Given this list of marker genes Il27ra, Ephb6, Pdcd1, Ddx21, H2-T15 (NCBI Gene Id 15030), Pik3r6 (NCBI Gene Id 432574), Ighv2-4 (immunoglobulin heavy variable V2-4), Slc11a1, Ighv1-56, Ighv13-2, Kmt5c, Ighv8-11, Ighv8-9, Slc18a2, Vsir, Nfkbiz, Swap70, Muc4, Klrc3, Ighv8-13, Ighm, Gpr15lg, Ighv8-6, Ighv2-5, Dlg1, Il9, Ighv16-1 (NCBI Gene Id 629812), Fcer1a, Stxbp2, F2, Chga, Ighv3-4, Ighv14-2, Rasgrp4, Prkcz, H2-Q4, Il18rap, Slc22a13, Mrgprx2, Il13ra2, Il21, Exo1, Cd40lg, Was, H2-M10.3, H2-T5, B2m, Stxbp3, Unc13d, Nppc, Vamp2, Il31ra, H2-Q7, Pik3r1, Stard7, Cd1d2, Zp3, Klrb1b, Shld2, Tnf, Foxp3, Hfe, Ighv5-9, Slamf9, Ticam1, Arg1, Cd160, Bst2, Nlrp3, Serpinb9h, Crk, Slamf1, Myo1g, Ripk3, Klrk1, Vav1, Rnf19b, Ighg1, Inpp5d, Trpm4, Trex1, Cd55, Nsd2, Ms4a2, Il7r, Ighv1-34 (NCBI Gene Id 634275), Tlr2, Atad5, Cd2, Ighv9-1, Ighv7-1, Spn, Ighv1-71, Fcer1g, Fes, Hmces, Nectin4, Klrb1c, H2-T3, Lilrb4b, H2-Q10, Pik3cb, Tbx21, Dusp22, Anxa3, Ighv1-64 (NCBI Gene Id 380823), Unc93b1, Rnf168, Ighv3-3, Il18r1, Ighv5-6, Crtam, Clec2d, Fzd5, Ighv5-12-4, Slc15a4, Gata3, Lamp1, Pcyox1l, Ctsc, Bcl10, Nlrp6, Jagn1, Ighv1-66, Dao, Scimp, Gzmm, H2-K1 (histocompatibility 2, K1, K region), Ighv2-9, Ighv8-12, Ighg2c, Adora2b, Supt6, Ighv1-54 (NCBI Gene Id 211331), Igll1, H2-M10.2, Jag1, Cd177, Stat5b, Fcrlb, Il4ra, C8a, Ighv1-31, Sh2d1b2, Rac2, Cd19, Gzmc, Nr4a3, Lilrb4a, Il12a, Pla2g3, Ighv1-43, Cd84, Lypd10, Ighv1-58, Pomc, Ywhag, Mavs, Il1b, Ceacam1, Klri2, Hmox1, Pvr, Stat6, Ncr3-ps, Ighv1-15, Cd46, Spi1, Ighv8-2, Ywhaz, Klrc1, Ighv14-3, Clec7a, Ppp3cb, Rab44, Tnfsf13, Cd74, Ighv8-5, C1s1, Ighv1-39, Ighv9-4, Ighv3-5, Fut7, Ighv1-55, Tap2, Cd55b, Trem3 (triggering receptor expressed on myeloid cells 3), Pagr1a, Fcgr3, Lig4, Scn11a, Ifng, Ighv1-47, Aplf, Ighv1-67, Calhm6, Cd226, Ccr2, Dbh, Grp, Ighv2-2, Sanbr, Il12b, Ighv2-7, Spon2, C1qc, Sh2d1b1, Ighv2-3 (immunoglobulin heavy variable 2-3), Rab27a, Gba1, Nbn, Bcr, Mbl2, Cd274, Rasgrp1, Fosl2, Cadm1, H2-T24, Grb2, Ighv1-76, Clec4g, Smad7, Cfh, Jak3, Raet1e, Ighv6-5, Ighv1-62-3, Azgp1, Ctsg, C1s2, P2rx7, Lyn, H60c, Plcg2, Mrgprb1, Fcgr2b, Cd70 (NCBI Gene Id 21948), Ighv1-49, Lat2 (linker for activation of T cells family, member 2), Tnfsf4, Ighv1-4, H2-M10.6 (histocompatibility 2, M region locus 10.6), Kctd9, Ighv1-63, Pdpk1, Ighg2b, Iglc3, Ager, Klrc2, Itgb2, Fgl2, Cx3cr1, Clnk, Mill1, Ighv3-8, Dnase1, Lag3, Ighv1-84, Fcmr, Rftn1, Ddx1 (NCBI Gene Id 104721), Cd300a, Ighe, Rigi, Arl8b, Pou2f2, Clcf1, H2-T23, Prdx1, C9, Ndfip1 (Nedd4 family interacting protein 1), Il6, Crhr1, Ighd, Ighv6-3, Raet1d, Il25, Ung, Ighv9-3, Cd300lb, Hmgb1, Ap1g1, Tfrc, Ighv11-2, Ighv4-1, C3, Cxcl5, Ighv1-78, Cbl, Mad2l2, H2-M10.5, Aire, Nppa, Plekhm2, Adora3, Tyrobp, Ighv14-4, Icam1, Ighv5-4, Mlh1, Cfi, Fadd, Cd80, C2, Csf2rb2, Igf2, C1rl, Cyrib, Il4, Il2, Zbtb1, Ighv2-6, Ighv1-16, Klre1, Klrb1, Ighv2-6-8, Vamp8, Ighv11-1, Sh2d1a, Snap23, Fgr, Map3k7, Serping1, Cd24a, Cd1d1, Exosc3, Shld3, Btk, Crp, Lyst, Malt1, Slfn2, Dennd1b, Ighv6-4, Pcyt1a, Gimap3, Serpinb9d, Cd96, Ncf1, C1qb, Cd28, Ighv3-1, Ccl2, Ighv5-16, Hc, H60b (NCBI Gene Id 667281), Trem1, Ighv1-72, Iglc1, Ighv1-11, Gzmb, H2-Q6, Rif1, C1qbp, Tlr3, Ighv6-6 (immunoglobulin heavy variable 6-6), Ebag9, Rnf8, Ptprc, Lep, Enpp1, Ighv1-42, Ace, Lta (lymphotoxin A), Kdm5d, Serpinb9g, Zp3r, Sphk2, Fas, H2-DMa, Gata1, Fbxo38 (NCBI Gene Id 107035), Tgfb1, Ptafr, Ptgdr, H2-M9, Fcer2a, Masp2, Coro1a, Card9, Pnp, Cdh17, Ifnb1, Clec12b, Tlr9, Ighv12-3, Shld1, Ighv1-23, Ptpn6, Ighv1-85 (immunoglobulin heavy variable 1-85), Serpinb9e, C4b, Ighv1-12, D6Wsu163e, Ighv10-1, Ighv8-8, Ufl1, Arid5a, H2-M5, Pram1, Ctsh, Iglc2, Wdr1, Pi4k2a, Ccr6, Ighv1-81, Ighv1-50, Hpx, Ulbp1, C8b, Ighv1-22, Lat, Fcgr4, Exosc6, Il2rb, Slamf6, Ighv8-4, Stat5a, 6030468B19Rik, Gcnt3, Cplx2, Tnfrsf1b, Gfus, Kdelr1, Bcl6, Ighv1-24, Rsad2, Fcgr1, Klrb1f (NCBI Gene Id 338509), Prf1, Ptgds, H2-Ea, Havcr2, H2-T13, Prkcd, 2410137M14Rik, Ighv2-9-1, Nkg7, Ighv6-7, Itgam, Myo1f, Irak4, Il13, Tusc2, Stx7 (NCBI Gene Id 53331), Dnase1l3, Snx4, Traf3ip2, Gapt, Cr1l, Serpinb9, H2-M3, Il20rb, Il9r, Trp53bp1, Myd88, Dpp4, Klri1, Ighg3, Nckap1l (NCBI Gene Id 78813), Ulbp3, Cd81, Gzmn, Tlr4, Pikfyve (phosphoinositide kinase, FYVE type zinc finger containing, NCBI Gene Id 71407), BC037156, C1qa, C8g (complement component 8, gamma polypeptide), H2-M2 (histocompatibility 2, M region locus 2), Klrb1a, C4bp, Mbl1, Klrd1 (NCBI Gene Id 16643), Gab2, Msh2, Cd8a, Mir181b-1, Treml4, H2-M10.1, F2rl1, Mr1, H2-M1, Il23r, Tcirg1, Prkaa1, Xrcc4, H2-M10.4, Xcl1, Milr1, Hspa8, Ighv1-61, Ercc1, Stx11, Msh6, Itgb2l, Elane, Ahr, Ighv9-2, Hprt1, Cd40, Ighv1-53, Icosl, Syk, Ighv1-77, Ighv3-6, Ighv1-5, Ighv1-7, Kit, Kmt5b, Abr, Stxbp1, Parp3, Ighv1-82, Hcst, Ndst2, Susd4, Ighv10-3, Aicda, Traf2, Ccl3, Traf6, H2-M11, Tac4, Ighv7-3, Gimap5, Il18, Stap1, Serpinb9f, Batf, Serpinb9c, H2-Q2, Ighv5-12, C1ra, Bcl3, H2-T22, Pms2, Pirb, Foxj1, Kif5b, Rabgef1, Nectin2, Stx4a, Igha, Kmt2e, Klhl22, Scnn1b, Sash3, Ighv14-1, H2-Q1, Il23a, Paxip1, Ighv1-75 (NCBI Gene Id 622728), Csf2rb, Serpinb9b, Pld2, Ighv1-26, Il4i1, Gata2 (GATA binding protein 2), Nod2 (nucleotide-binding oligomerization domain containing 2), Ighv5-17, Lypd11, Lgals9, Arrb2, Gfer, Crlf2, Tap1, Irf7, Mir181b-2, Emp2, Hspd1, Ighv1-80, Cr2, C1rb, Cebpg, Cxcl1, Ccl20, Dhx36, Trem2, Il1r1, H2-D1, Foxf1, here is a description of the gene set: Any process involved in the carrying out of an immune response by a leukocyte. Mouse Gene Set: GOBP_LEUKOCYTE_MEDIATED_IMMUNITY studied in species Mus musculus